The following is a description of a gene set: Mouse Gene Set: GOBP_RESPONSE_TO_CORTISOL studied in species Mus musculus Any process that results in a change in state or activity of a cell or an organism (in terms of movement, secretion, enzyme production, gene expression, etc.) as a result of a cortisol stimulus. Cortisol is the major natural glucocorticoid synthesized in the zona fasciculata of the adrenal cortex; it affects the metabolism of glucose, protein, and fats and has appreciable mineralocorticoid activity. It also regulates the immune system and affects many other functions., and this is the list of marker genes: Slit3, Cyp1b1, Gkn2, Nr3c1, Cad, Klf9